Given this list of marker genes AKIRIN2, AKAP8L, MED24, GIT2, ODAD3, IWS1, MTF2, ARMC8, PIAS3, SCYL3, METTL3, BTF3, MIOS, ATP6V0C, JARID2 (jumonji and AT-rich interaction domain containing 2), AKAP8, JMJD6, PIGV, CNOT1, MAGT1, TRA2A, PITX1, CIPC, INTS9, METTL16, PAFAH1B1, UBC, PTMA, ARCN1, ABHD12, GAPDH, NCOA6, USP14, RAB4B, U2AF2, UBA1, CD164, TET2, ARPC2, NCAPH2, RFX1, DOCK8, EIF5, UTP20, SZRD1, CCDC174, C21orf58, PHF12, UBE2K, MARK3, MPDU1, DZIP1, FAM83H, PPP1R21, ZC3HC1, CHD2, RUFY1, POLR2A, WASL, EIF4G2 (eukaryotic translation initiation factor 4 gamma 2), PRDM10, RPRD1B, CBX5, CCNK, UQCRH, GNAO1, CRKL, ZNF207, PNRC2, RAB28, CHCHD10, PDE4D, RXRB, WIPI2, RNF5, DOLK, ILF3-DT, BCL2L13, STRN3, ENOX1, USF1, PLPBP, PIAS1, IDH3G (isocitrate dehydrogenase (NAD(+)) 3 non-catalytic subunit gamma), TMED10, RSRC2, ATRX, ZNF747, KNTC1, SPNS1, SETD3, ATP5F1A, MAP3K4 (mitogen-activated protein kinase kinase kinase 4), UBAP1, IRAK1, PRICKLE3, HMBOX1, ING4, SCAF8, RPL10, TRIM8, SUMO2, NACA, SRSF2, PPP1R15B, SLC26A6, APBB1, SMYD5, RBMX, PPP1CC, DISP2, ADNP, TTI1, ZFAT, CCNB1IP1, LIMA1, DYRK1B, SNX13, ZBTB4, CCDC71, PCNT, KAT7, SNRNP35, DSCAM (NCBI Gene Id 1826), COX8A, KIF1B, RALA, TBC1D14, MAEA, KPNA6, RBMS1, RACGAP1, ELK3, JPT1, ATP5MC1, NAPEPLD, TUG1, TCF4, PFN2, MTMR3, CASC3, HNRNPH3, TSC1, OARD1, GPBP1, N4BP2L2, EIF2B4, RPRD1A, SPEF1, SRSF3, ARFGEF1, GNAI2, ZFY, ATF1 (activating transcription factor 1), RBM10, RBM39, FOXN3, MAP2K5, ZNF668, SF3A1, GFER, ADAM11, SLC6A1, TTLL11, KANSL2, TGIF1, CELF1, GRIN2B, PCBP4, SMCR8, BOP1, EIF4A1, ZBTB22, RPN1, STRN4, KCNMA1, DUSP7, SFPQ, WDR13, FBXL18 (NCBI Gene Id 80028), AP3D1, RALGAPA1P1, GIGYF2, PYM1, SP1, CDK17, C9orf163, AIP, NSF, EP300, PSPC1, PMF1, RABL6, LRRC41, KLHL28, CCDC6, ZBTB11, RBM4B (RNA binding motif protein 4B), ASXL2, RECK, AEBP2, ADGRL1, PRRC1, PPP2CA, R3HDM1, RRM1, ING3, SCRN1 (secernin 1), SRGAP2, DDX17, CSNK1A1, REXO1, ACTR8, RAB1A, ARHGEF17, NUDT3, PUM1, BTRC, CNOT3, SSR4, EZR, KDM2A, TGM5, IST1, CHTOP, MOK, ZFP37, TMEM187, TIA1, TAF6, PPP2R2A (NCBI Gene Id 5520), CNPY4, LSM14A, PRPSAP2, EXOC6, NFYC, HSPA8, DHX35, NELFA, CSNK1A1L, HNRNPA1, UBE2J2, PPP4R2, FOXP1, PTBP1, CACNB2, AGPAT1, LMF2, TOMM40L, MYNN, RAB22A, FAM162A, HIC2, RIF1, BAMBI, DAP3, SAFB, MRPL51, ZNF638, EPC2, CPSF2, TAF15, CD4, HMGXB4, NDUFB1, SHANK2, SEC23A, ATE1, RLIM, SLC39A7, SRSF1, ELAVL4, RBM3, WDR77, HEXIM2, SRSF7, CTCF, NDUFS8, RAD21, PRPF38B, ZNF335, APLP1, NFYA, KMT2E, RBM12, UGGT1, SPCS2, HOXC4, ATF4, PHB2, ZDHHC5, RAPGEF4, CCND2, DDX6, UBA52, PSMC5, CLK4, HNRNPC, CSE1L (NCBI Gene Id 1434), LMNB1, GBF1, NUFIP2, LUC7L3, C3orf36, ATP5PB, METTL4 (methyltransferase 4, N6-adenosine), FTSJ3, CELSR3, ADO, HSF1, RPS6KA3, TJAP1, SYT11, RBM5, PCF11, PAPOLB, ETV1, ANAPC4, RAB5A, RBFOX1, UBXN11, OTX2, CAB39L (calcium binding protein 39 like), EMSY, AP4S1, ABHD1, MAT2A, DENND4A (NCBI Gene Id 10260, DENN domain containing 4A), SNX5, RBM14, PPP4R3B, RPL18A, SNX17, EEF1B2, MANF, FAM193B, RPL35A, KDM3A, NCDN, ANGPTL5, SYNE2, MRPL1, EPC1, TPGS2, NDUFS1, UBE3A (ubiquitin protein ligase E3A), TOGARAM1, HIF1A, FZD8, YWHAE, NDC80 (NDC80 kinetochore complex component), FKRP, IRS4, ARID4A (NCBI Gene Id 5926), WSB1, TRAPPC8, YY1AP1, KDM6A, TTC17, PRRC2C, ZBTB40, UBIAD1, SRSF5, EXOC7, MAP4K3, PDSS2, ZNF143, ALKBH8, IRX5, EMG1, PAPOLG, PCIF1, PRKCSH, ZNF41, CLPB, TRA2B, TP53BP1, EMC6, DDX3X, NCAPD2, ATP5MC2, THAP1, HOXA2, H1-0, CPNE1, ILF3, DYNC1H1, RPP25L, AP1G1, L3MBTL2, HAPSTR1, ZNF318, RNF26, NASP, HOXC6, RPS8, ARF1, LYPLA2, MGME1, MRPL11, YBX1, ZNF764, TOP3A, COX7B, FAM120C, SFXN1, FBXL19-AS1, ENSA, NR2C2, FUS, RAB10, NBEA, UPF3B, MNT, TCTN2, DGCR2, TSPYL2, RCC1L, NFE2L1, KIAA1143, TAX1BP3, CDKN1B, PICK1 (NCBI Gene Id 9463), ZFX, KIF15, PDS5B, ZNF646, ADK, LRRC4, UBR3, SERBP1, TMEM69, FOXN2, TIAL1, POU2F1, TARDBP, PCYT2, here is a description of the gene set: from publication Xie X, Lu J, Kulbokas EJ, Golub TR, Mootha V, Lindblad-Toh K, Lander ES, Kellis M (PMID 15735639) species: Homo sapiens Genes having at least one occurrence of the highly conserved motif M10 GCCATNTTG in the regions spanning 4 kb centered on their transcription starting sites. This matches the YY1 transcription factor binding site V$YY1_Q6 (v7.4 TRANSFAC). Human Gene Set: GCCATNTTG_YY1_Q6 Comprehensive identification of all functional elements encoded in the human genome is a fundamental need in biomedical research. Here, we present a comparative analysis of the human, mouse, rat and dog genomes to create a systematic catalogue of common regulatory motifs in promoters and 3' untranslated regions (3' UTRs). The promoter analysis yields 174 candidate motifs, including most previously known transcription-factor binding sites and 105 new motifs. The 3'-UTR analysis yields 106 motifs likely to be involved in post-transcriptional regulation. Nearly one-half are associated with microRNAs (miRNAs), leading to the discovery of many new miRNA genes and their likely target genes. Our results suggest that previous estimates of the number of human miRNA genes were low, and that miRNAs regulate at least 20% of human genes. The overall results provide a systematic view of gene regulation in the human, which will be refined as additional mammalian genomes become available.